Given this list of marker genes BUB1, PSMF1, PPP3R1, SLC39A14, MICU2, PRRC2C, EIF4E, RCE1, EBP, PGD (NCBI Gene Id 5226), MRPL12, PDE3B, KPNB1, CD7, ELP1, TES (testin LIM domain protein), DNAJC11, MSMO1, SLC38A10, TUG1, ZNF428 (zinc finger protein 428), SATB1, CST7, HDAC4, PPP6C, MYOF, MAP3K14, CEP43, ENTREP3, SF3A1, MFN1, ABHD14A, AKAP9, YIPF3, AK4, ZMYM4, SMARCC1, IFNGR1, CDH17, NTRK1, NME4, MMP8, LRRN3, LRRC42, MAD2L1, JARID2, STK39, IMPG1, CNTN1 (NCBI Gene Id 1272), ACO2, DAPK1, NUP98 (nucleoporin 98 and 96 precursor), HERC3, PDXK, H1-2 (NCBI Gene Id 3006), KAT6B, OAZ1 (NCBI Gene Id 4946), GALNT3, ATP6V0A2, PPIA, DCK, MPRIP, MAL, CLIC5, ST8SIA4, PDE8A, TUBGCP3, TUBA1B, EHMT2, IL10RA, RCN2, AIMP1, STK10, TDG, NUP50, SERTAD2, CDC25B, EIF4G1, KDM3B, FLI1, BYSL, SRGN, NHERF1, GPNMB, DLG1, ALDH9A1, RYK, FDFT1, ACADM, GATA3, WIPF2, KLF6, NFATC2IP, TENT4A, BLMH, CSPG5, NUDC, PPP1R12A, GZMB, GCLM, AGGF1 (angiogenic factor with G-patch and FHA domains 1), FOXN3, HPCAL1, CHD4, GPX7, ITPR1, STK17B, MLF2, TRIP4, ST6GAL1, MGRN1, GIGYF2, TRIM15, UBR5, HNRNPM, ACAT2, CSTB (NCBI Gene Id 1476), IGF2BP3, PRKD2, ACSL3, VEGFA, ACLY, MARCKS, TRAM1 (translocation associated membrane protein 1), ATRX, UFD1, OSGEP, BRD3, MTHFS, GPX1, ARHGAP25, GPR18, PSD4, RGS19, AOAH, RBM14, IL1A, GOLGA8A, BAG1, BCKDK, ELAVL1, FXN, BCL2A1, GPR183, ZFP36 (ZFP36 ring finger protein), MPP1, ANAPC10, GALR2, ARHGEF9, CLN5, EXT1, KATNA1, SPINT2, FRMD4B, UBE2S, PBX3, YAF2, RANBP1, ELP4, NIPSNAP1, RERE, ERCC1, CTR9, CD28, SSB, TP53BP2, BACH1, PHF8, REEP5, MTMR6, COG5, ERCC4, TOM1, DPYD, MAPRE2, BAG6, APP, RABEPK, TXNDC9, POP7, SEC24A (SEC24 homolog A, COPII coat complex component), SCFD1, BAG2, IL1R1, BPTF, AKR7A2, SDR39U1, CREB1, KIF2A, PAF1, CCN6, GNA15, RSRP1 (arginine and serine rich protein 1), HS2ST1 (heparan sulfate 2-O-sulfotransferase 1), ATP5F1D, PRKY (protein kinase Y-linked (pseudogene)), FANCI, CLSTN3 (calsyntenin 3), ABCD3, SAP30, here is a description of the gene set: from publication Hurtz C, Hatzi K, Cerchietti L, Braig M, Park E, Kim YM, Herzog S, Ramezani-Rad P, Jumaa H, Müller MC, Hofmann WK, Hochhaus A, Ye BH, Agarwal A, Druker BJ, Shah NP, Melnick AM, Müschen M (PMID 21911423) Human Gene Set: GSE24814_STAT5_KO_VS_WT_PRE_BCELL_DN In order to investigate the function of STAT5 in ALL, we isolated bone marrow cells from STAT5 fl/fl mice and transformed them with BCR-ABL1. In a second transduction the BCR-ABL1 driven pre-B cells were transformed either with CRE-GFP or empty vector control (GFP) and subjected to gene expression analysis. species: Homo sapiens Genes down-regulated in pre-B cells: STAT5 knockout versus wildtype.